The following is a description of a gene set: Human Gene Set: GOCC_POSTSYNAPTIC_DENSITY_MEMBRANE The membrane component of the postsynaptic density. This is the region of the postsynaptic membrane in which the population of neurotransmitter receptors involved in synaptic transmission are concentrated. studied in species Homo sapiens, and this is the list of marker genes: LRFN5, LRFN1, GRIN3A, EFNB2, CLSTN2, CACNG5, CACNG7 (calcium voltage-gated channel auxiliary subunit gamma 7), FGF22, CACNG8, IGSF9, GRIK5, GRIA2, ATP2B2, NEO1, SEMA4C, GRIK2, TRAPPC4, LRRC4C, LRFN3, CACNG4, IGSF21, GRIA3, NETO1, ABHD17C, SHISA9, GRIN2D, NLGN4X, RGS7BP, SORCS2, TMEM108, DLG2, LRRTM2, GRID2, LRRC4, GRID1, GRM1, CACNA1C, GRM5, ADRA2A, LIN7A, SEMA4B, GSG1L, OPRD1, SORCS3, GRIK3, SLC16A7, PLPPR4, DLG3, KCNH1, SLITRK1, DAGLA, ITGA8, LRFN4, NLGN4Y, CHRM1, CRHR1 (NCBI Gene Id 1394), CLSTN3, NETO2, ACTN2, LIN7C, NRCAM, GRIN2C, PRRT1, PRR7, KCNK2, GRIN1, ABHD17A, TMEM240, RYK, CACNG2, NECTIN3, CSMD2, SHISA6, CNKSR2, VANGL2, SEMA4F, ELFN2, SCRIB, PRRT2 (NCBI Gene Id 81865), PTPRO, EPHA4, GRIN3B, GPR158, ASIC2, LRP8 (LDL receptor related protein 8), LIN7B, EPHA7, ABHD17B, PTPRS, GRIN2A, ERBB4, GRIA1, ANP32E, LRRTM3, SLC30A1, SLITRK5, ADGRB3, ELFN1, RNF10, SYNDIG1, DLG1 (NCBI Gene Id 1739), LRRC4B, SHISA7, ASIC1 (NCBI Gene Id 41), ADAM22, RGS9, DLG4, GRIK4, GRIA4, NOTCH1, GRIN2B, AKAP9, NSG2, CACNG3, SLITRK3, GRIK1, DCC, SIGMAR1, LRFN2, ADCY1, STX1A